Given this list of marker genes HAND1, CDAN1, CDC34, NHLH1, OR4D1, ST6GALNAC3, CENPT, RABGEF1P1 (RABGEF1 pseudogene 1), PPBPP2, NOS1, CTAGE1, LGR5, ANGPTL1, EPB42, POU2F2, GABRA4, GRK5, SOS2, SERPINA1, SLC26A6, OR10H1, GRM6, LINC01150, ZNF668, PRRT1, EFCAB6, HYMAI, STATH, PCLO, TMEM92-AS1, OR9A1P, NKAIN1, SMR3B, CRHR2, MS4A6A, LINC01587, EPOR, S1PR2, SPATA7, PRLHR, NXPE4 (NCBI Gene Id 54827), MOGAT2, DRD5, TNFRSF11A, TAGAP, C2orf72, BVES-AS1, SFXN5, EPHB2, TSHB, CA7, SLCO3A1, SPARCL1, CASQ2, SYT5, RSPH14, here is a description of the gene set: We have exploited a discrepancy in the oncogenic potential of autocrine and exogenous human growth hormone (hGH) in an attempt to identify molecules that could potentially be involved in oncogenic transformation of the human mammary epithelial cell. Microarray analysis of 19,000 human genes identified a subset of genes in a human mammary carcinoma cell line that were remarkably different in their response to autocrine and exogenous hGH. Autocrine and exogenous hGH also regulated 167 common genes. Semiquantitative reverse transcription-PCR confirmed differential regulation of genes by either autocrine or exogenous hGH. Functional analysis of one of the identified autocrine hGH-regulated genes, TFF3, determined that its expression is sufficient to support anchorage-independent growth of human mammary carcinoma cells. Small interfering RNA-mediated knockdown of TFF3 concordantly abrogated anchorage-independent growth of mammary carcinoma cells and abrogated the ability of autocrine hGH to stimulate oncogenic transformation of immortalized human mammary epithelial cells. Further functional characterization of the identified subset of specifically autocrine hGH regulated genes will delineate additional novel oncogenes for the human mammary epithelial cell. Genes up-regulated in MFCF-7 cells (breast cancer) by exogenous HG1. Human Gene Set: XU_GH1_EXOGENOUS_TARGETS_UP studied in species Homo sapiens from publication Xu XQ, Emerald BS, Goh EL, Kannan N, Miller LD, Gluckman PD, Liu ET, Lobie PE (PMID 15845533)